Given this list of marker genes Map1lc3b, Map1lc3a, Anxa11, Rs1, Trem2, Esyt3, Pltp, Cd300a, Pemt, Gabarapl1, Gabarap, Esyt2, Nf1, Esyt1, Gabarapl2, here is a description of the gene set: Binding to a phosphatidylethanolamine, a class of glycerophospholipids in which a phosphatidyl group is esterified to the hydroxyl group of ethanolamine. Mouse Gene Set: GOMF_PHOSPHATIDYLETHANOLAMINE_BINDING studied in species Mus musculus